Given this list of marker genes Trim38, Trim11, Hmgb1, Vps4a, Furin, Clec4g, Cd74, Cd209c, Lgals1, Axl, Bsg, Cd4, Fmr1, P4hb, Cd209e, Kpna2, Tsg101, Tyro3, Trim30a, Smpd1, Kpna6, Tmprss4, Vps37b, Tmprss2, Cd209d, here is a description of the gene set: Any process that activates or increases the frequency, rate or extent of viral life cycle. Mouse Gene Set: GOBP_POSITIVE_REGULATION_OF_VIRAL_LIFE_CYCLE studied in species Mus musculus